Given this list of marker genes FCER1G, SYK, BCL10, KIT (KIT proto-oncogene, receptor tyrosine kinase), NR4A3, here is a description of the gene set: species: Homo sapiens Human Gene Set: GOBP_POSITIVE_REGULATION_OF_MAST_CELL_CYTOKINE_PRODUCTION Any process that activates or increases the frequency, rate, or extent of mast cell cytokine production.